The following is a description of a gene set: studied in species Mus musculus Mouse Gene Set: GOMF_PHOSPHATIDYLINOSITOL_3_KINASE_INHIBITOR_ACTIVITY Binds to and decreases the activity of a phosphatidylinositol 3-kinase (PI3K)., and this is the list of marker genes: Wdr81, Washc1, Pik3ip1, Atg14, Rubcn, Wdr91